The following is a description of a gene set: Genes up-regulated in comparison of dendritic cells (DC) stimulated with LPS (TLR4 agonist) at 0.5 h versus DC cells stimulated with poly(I:C) (TLR3 agonist) at 0.5 h. from publication Amit I, Garber M, Chevrier N, Leite AP, Donner Y, Eisenhaure T, Guttman M, Grenier JK, Li W, Zuk O, Schubert LA, Birditt B, Shay T, Goren A, Zhang X, Smith Z, Deering R, McDonald RC, Cabili M, Bernstein BE, Rinn JL, Meissner A, Root DE, Hacohen N, Regev A (PMID 19729616) Human Gene Set: GSE17721_LPS_VS_POLYIC_0.5H_BMDC_UP mouse primary BMDCs were stimulated with tlr ligands and gene expression changes were profiled on Affymetrix arrays species: Homo sapiens, and this is the list of marker genes: ITIH3, MLLT3, FBXL20, KLHDC2, KIF13A, C2orf76, MAP3K8, NDUFS6, CLUAP1, CTDP1, FEZ2, MOGS, GKN1, BCAP31, FASTKD5 (NCBI Gene Id 60493), HARS1, TMEM242, NSMF, GLUL, FUCA2, ASAH2, NFATC1, DENND4C, LRRC42, ILRUN, GALNT6, MR1, ACSL6, DNM3, MAX, MGAT4C, GPATCH2, CXorf38, NUCKS1, ANTXR2, IL12RB2, EOLA1, CASQ2, ADAM10, AQP8, DFFA, CYP1A1, NUP58, DPP3, NUDT9, RMC1, GRWD1, BLM, NAB1, CLIP4, MVK, GIMAP6, HDAC2, MRPL42, HOMER2, CD248, DMXL1, AIG1, HNRNPK, NOP2, DCT, ZSWIM9, GRSF1, BBLN, MPV17, COA3, EDC4, CDO1, MOB4, AMMECR1L, HECTD1, GOLGA7, NSG1, ARHGAP12, FIG4, HSPB3, ANKRD46, DYSF, CNTN2, FLT3, CITED2, MRPL12, C11orf52, NEUROG3, MPDZ, ACVR1, GALK2, FOXP1, CDC25A, GNG12, RETREG3, KCNN1, DNAJB13 (NCBI Gene Id 374407), GRIK5, KCNIP3, LETMD1, NUCB2 (nucleobindin 2), GNA14, TLNRD1, GNAQ, CELF1, MBP, ATN1, H1-8, AQP9, FCGR1A, CCKBR, DHX8, CTC1, GRIA2, MLXIP, EVI5, DIS3, H2BC3, RETREG2, MTAP, ACSM1, APOM, ITGB3BP, NSUN2, ACAD10, DDX5, ACTN2, MRPL37, KCNN4, ARHGDIB, ANLN, KRTCAP2, GFM1, GABPA, CLPTM1L, MAGOHB, CACYBP, DUSP12, METRNL, KIF21A, CNTN6, NPPC, CTLA4, AP1S1, FGFBP1, MRPL1, CPEB2, LTBP2, MGLL, NUDC, MARK2, ASZ1, GIT1, AGRP, CROT, ERI1, AKAP10 (NCBI Gene Id 11216), MXI1, NUP37, EEFSEC, GAA, CASC3, CCR1, NRARP, GABRA6, SLC25A51, HSD17B8, BOP1, CENPB, EXT1, KDELR1, NUP188, MRPL18, ARTN, NUB1, CHRNB2 (NCBI Gene Id 1141), SPIDR, IFT88, NEK6, FXYD4, FMO2, KCNAB2, HEXA, LRP4, LIMK2, NAT1, MTF2, CCNL1 (cyclin L1), HTR2B, TPGS1, LRRC59, ELF1, C5orf15, BNIP1, DAPP1, MMP23B, AGR3, JAK1, QNG1, HABP4, MRTFB, MARK4, DOK5, MRPS25